Given this list of marker genes Lce3b, Plekha4, Mrps18a, S100a8, 4921517D16Rik, Srsf1, Lypd2, Sdr9c7, Suclg2, Cx3cl1, Sprr2h, Batf3, Samhd1, Qdpr, Sprr2k, Pmepa1, Chka, Icam1, Tmem65, Eef1d, Mgat1, Klk9, Axl, Ftl2-ps, Eml4, S100a11, Mt1, Gsk3b, Rab2b, Pds5b, Camk4, Gdf5, Prg3, Rpl39, Ssu72, Mcam, Hexa, Nek4, Lif, Sprr2g, H2az1, Rasip1, Prrc1, Nfe2l2, Tnfrsf25, Enah, Gsta1, Serpinb3c, Foxl2, Ryr1, Ldha, 1700105P06Rik, Ly6e (NCBI Gene Id 17069), 2900064F13Rik, Map6, Pgk1, Pfkl, Ltb4r1, Fabp4, Pdcd5, 2610042L04Rik, Jag1, Cspp1, Drd5, Prss3b, 1110038B12Rik, Stx16, Gkn3, Ptprcap, Ncan, Spic, Art5, Psg28, Dnajc1, Fes, Txn1, Chi3l1, Ube2c, Galk1, Selenot, Ppic, Klf13, 4930556N13Rik (NCBI Gene Id 75285), Sprr2i, Cct4, Cmpk2, Elapor1, Eno1, Ncl, Rnase2b, Rab5if, Smim8, Acot10, Acan, Creld1, Hrc, Bzw1, Ugt2b37, Hbb-y (NCBI Gene Id 15135), Sprr2f, Trmt1, Esd (esterase D/formylglutathione hydrolase), Sprr2b, Eef1b2, Bbln, Ifitm3, Dynll1, Rps3a1, Sun1, Il36a, Lrif1, Ftl1, Sfpq, Srm, Cox19, Chpt1, Trp73, Racgap1, Cacybp, Id1, Arg1, Cxcl16, Snhg3, Clvs1 (clavesin 1), Gpr15lg, Wfdc2, Elavl1, Rhoh, 4930527J03Rik, Bid, Or8b12i, Rps6ka4, Pgam1, Psg23, Stfa1, Snhg9, Slpi (secretory leukocyte peptidase inhibitor), Homer3, Gclm, Cd248, Kprp, Sfn, Calm4, Il1b, Tmem248 (NCBI Gene Id 77960), 4930547E14Rik, Traf2, Klk6, Fam162a, H2-M9, Morn5, Eng, Nrsn1, Rubcn, Tgfa, Saraf, Ext2, Hspd1, Ide, Hamp, Nhp2 (NHP2 ribonucleoprotein), Bmyc (NCBI Gene Id 99306), Hbs1l, Spns3, Rptn, S100a9, Vps37a, Cox5b (NCBI Gene Id 12859), Ccdc38, Cacna1e, Vhl, here is a description of the gene set: from publication Darwiche N, Ryscavage A, Perez-Lorenzo R, Wright L, Bae DS, Hennings H, Yuspa SH, Glick AB (PMID 17525749) Chemical induction of squamous tumors in the mouse skin induces multiple benign papillomas: high-frequency terminally benign low-risk papillomas and low-frequency high-risk papillomas, the putative precursor lesions to squamous cell carcinoma (SCC). We have compared the gene expression profile of twenty different early low- and high-risk papillomas with normal skin and SCC. Unsupervised clustering of 514 differentially expressed genes (P<0.001) showed that 9/10 high-risk papillomas clustered with SCC, while 1/10 clustered with low-risk papillomas, and this correlated with keratin markers of tumor progression. Prediction analysis for microarrays (PAM) identified genes that distinguished the two papilloma classes, and a majority of these had a similar expression pattern in both high-risk papillomas and SCC. Additional classifier algorithms generated a gene list that correctly classified unknown benign tumors as low- or high-risk concordant with promotion protocol and keratin profiling. Reduced expression of immune function genes characterized the high-risk papillomas and SCC. Immunohistochemistry confirmed reduced T-cell number in high-risk papillomas, suggesting that reduced adaptive immunity defines papillomas that progress to SCC. These results demonstrate that murine premalignant lesions can be segregated into subgroups by gene expression patterns that correlate with risk for malignant conversion, and suggest a paradigm for generating diagnostic biomarkers for human premalignant lesions with unknown individual risk for malignant conversion. studied in species Mus musculus Genes up-regulated during skin tumor progression from normal skin to high risk papilloma. Mouse Gene Set: DARWICHE_PAPILLOMA_RISK_HIGH_UP